The following is a description of a gene set: Genes up-regulated in comparison of dendritic cells (DC) stimulated with LPS (TLR4 agonist) at 16 h versus DC cells stimulated with poly(I:C) (TLR3 agonist) at 16 h. mouse primary BMDCs were stimulated with tlr ligands and gene expression changes were profiled on Affymetrix arrays studied in species Homo sapiens from publication Amit I, Garber M, Chevrier N, Leite AP, Donner Y, Eisenhaure T, Guttman M, Grenier JK, Li W, Zuk O, Schubert LA, Birditt B, Shay T, Goren A, Zhang X, Smith Z, Deering R, McDonald RC, Cabili M, Bernstein BE, Rinn JL, Meissner A, Root DE, Hacohen N, Regev A (PMID 19729616) Human Gene Set: GSE17721_LPS_VS_POLYIC_16H_BMDC_UP, and this is the list of marker genes: IPO4, BOLA2, TUFM, CHID1, OSGIN1, UBXN2A, CLEC4D, IDH1, ECH1, AOAH, FKBPL, B3GALT2, HIBADH, SUOX, UROD, GCG, TXNDC5, DCTN3, FBL, OSBPL2, CYP4B1, SCAMP1, PWP1, PCBD2, IGBP1 (NCBI Gene Id 3476), OST4, RRP8, PTBP1, SRGN, AZIN1, CEP20, LIF, MRPS14, MRPL58, PPP2R3C, PTPN1, MCM7 (minichromosome maintenance complex component 7), RAC2, FAM149B1, BTG2, PRMT5, COPS6, MCM3, MYDGF, PPP4R2, GLO1, OLR1, UPF2, MYO5A, TIMM17B (NCBI Gene Id 10245), MRPL35, ATP2A2, ADPGK, RAB2A, ARFGEF1, GSTA5, LFNG, SLC1A2, HRC, ABHD17C, SEC63 (SEC63 homolog, protein translocation regulator), METTL5, STRAP, TGFBI, HCLS1, NOMO1, ACOX1, MLX, CRIPT, CIAO2A, GMPPA, IDH2 (isocitrate dehydrogenase (NADP(+)) 2), PRPS1, RNF141, PTPN11, FDPS, SPIC, SRSF10, C1GALT1C1, LANCL1, ANP32A, PRSS37, TANC1, IGF2R, QNG1, TUBGCP5, LSM2, LRPPRC (NCBI Gene Id 10303), CXCL14, LRRC57, SLF1, NFKBIB, POFUT2, MMACHC (NCBI Gene Id 25974), SPPL2A, CDC16, OR10J5 (NCBI Gene Id 81483), ITGA4, GLB1, LTA, YBX3, NR1H3, BST1, NCF1, SEC61G, GLG1 (NCBI Gene Id 2734), CYP51A1, CD48, MAP4K5, IFTAP, GAS7 (NCBI Gene Id 8522), TRAM1, SFXN3, NDUFV2, ALDH1A2, SLC7A7, HEATR6, FABP4, SMIM30, STMN1, YAE1, CDH6, NDUFA4, PLXDC2, ETV1, METTL6, MRPL45, ZDHHC6, DRG1, NKAP, CDK2AP1, RNF5, BABAM1, CYTH3, ZNF566, NDUFS2, RPF1, KCNIP4, LSG1, PON2, EIF3J, SHE, IFNAR2, CHST14, IFT22, NF2, SSBP4, ABCB6, AURKAIP1, CNOT7, AOX1, PPP6C, MNAT1, TEX2, RNASEH2C (ribonuclease H2 subunit C), HECTD1, PRADC1, DDHD2, DHRS3, DPH6, GUSB, MCTS1, CCT2, BPNT1, COQ3, MRPL23, PACC1, GTF2E2, HYPK, UTP11, RTN3, NUP43, BCKDHB, PDE4B, ASRGL1, RBBP7, TREM1, EIF3L, HEXB, CYB5R3, TDP1, FST, POLA1, ZNF830, SNRPD1, ARHGEF3, ATP5F1B, GUCA1A (NCBI Gene Id 387091), COX18 (cytochrome c oxidase assembly factor COX18), RAD18, COL4A2, WDHD1, ST13, STARD4, BLMH, SIT1, ZNF644, TRMT2A, UCK2, LCP1